Given this list of marker genes TULP3, A4GALT, IGFBP4, CH25H, RASGEF1A, DPYSL4, IL3RA, SQSTM1, P3H2, AMACR (NCBI Gene Id 23600), MYO10, ITGA2, GADD45B, SLC2A14, CSF2, F2RL1 (NCBI Gene Id 7901), FGF11, PLIN2, TARP, HYCC2, ENC1, POU2F1, PLEKHH3, CD83, SLC9A7, CD1B, TJP2, P4HA2, IL18RAP (interleukin 18 receptor accessory protein), DHRS3, CIART, SH3BP4 (SH3 domain binding protein 4), TRAF1, CYSTM1, CCR7, SMAP2, SPAG4, EMP1, GGT5, ADGRG5, PFKFB4, LAMP3, PSAT1, COL6A1, PIM1, SEMA6C (semaphorin 6C), CXCL8, TLE4, BTG1, EPB41, KISS1R, TRIM58, NFIL3, TGM2, ADM (adrenomedullin), TMEFF2, PIK3IP1, DAPK1, CCL3, IL18R1, PLVAP, CCL22, PLEKHA4, CD1A, NT5C3B, FBXO6, OSM, CDKN1C, FNDC3B, SPP1, IL7R, CCDC102A, DUSP5, TMEM116, CCND2, ST3GAL5, DIPK2A, KLF2, MAP1A, SAMSN1, UPK1A, CERCAM, EGFL6, CTSH, NCS1, TUBB2B, RNF217 (ring finger protein 217), CISH, HSPA2, SLC2A10, SLC25A4, SYNE3 (spectrin repeat containing nuclear envelope family member 3), TNFAIP8L3, TRIM46, CBS, PLXNA3, TP53INP2, SOS1, STK17B, STAP1, GPAT3, GNPTAB, FCGR2A, BHLHE40, FAM241A, DDIT4, GPR65, MAPK13, TNFRSF4, COCH, GYPB, PRDM8, HES6, BTG2, MOSPD3, GBP4, NAAA, BBX, SCHIP1, CLEC4A, MAOA, MIIP, HILPDA, OLR1, XIRP1, EGR1, CTXN1, IL4I1, PLAU, ARG2, CD40LG, PGM2L1, GABARAPL1, PRPS1, ST3GAL4, TGFBR1, FCER2, CTNS, GATA2, CXCL10, MTHFD1, BATF3 (NCBI Gene Id 55509), VASN, CDHR1, UBAC1 (NCBI Gene Id 51408), PHTF2, OSBP2, NIBAN2, CALB2, LTB, RGS1, PTGER2, TLE3, HBZ, MOB3B, FPR3, CA2, RHAG, TRIB1, TRIB3, RNF144A, DCPS, PHLDA1, SLC25A37, IGFBP5, RHEBL1, CFH, KRBA1, CST7, P2RX4, SOCS2, HOXB5, ABCA1, CKAP4, IL4R, TTLL7, NOD1, CTSZ, KLF6, MUC1, CCL5, SNTA1 (syntrophin alpha 1), TSC22D2, DAB2, RABGAP1, RAP1GAP, MEX3D, FAM131A, ENPP3, ARL4A, HSPA6, NTSR1, NAALADL1, ANTXR2, PCSK9, GALC, AK3, GNG2, CCL2, SLC6A9 (NCBI Gene Id 6536), CPXM1, NDRG1, here is a description of the gene set: studied in species Homo sapiens Genes up-regulated in CD34+ cells by intermediate activity levels of STAT5A; predominant long-term growth and self-renewal phenotype. The level of transcription factor activity critically regulates cell fate decisions, such as hematopoietic stem cell (HSC) self-renewal and differentiation. We introduced STAT5A transcriptional activity into human HSCs/progenitor cells in a dose-dependent manner by overexpression of a tamoxifen-inducible STAT5A(1*6)-estrogen receptor fusion protein. Induction of STAT5A activity in CD34(+) cells resulted in impaired myelopoiesis and induction of erythropoiesis, which was most pronounced at the highest STAT5A transactivation levels. In contrast, intermediate STAT5A activity levels resulted in the most pronounced proliferative advantage of CD34(+) cells. This coincided with increased cobblestone area-forming cell and long-term-culture-initiating cell frequencies, which were predominantly elevated at intermediate STAT5A activity levels but not at high STAT5A levels. Self-renewal of progenitors was addressed by serial replating of CFU, and only progenitors containing intermediate STAT5A activity levels contained self-renewal capacity. By extensive gene expression profiling we could identify gene expression patterns of STAT5 target genes that predominantly associated with a self-renewal and long-term expansion phenotype versus those that identified a predominant differentiation phenotype. from publication Wierenga AT, Vellenga E, Schuringa JJ (PMID 18779318) Human Gene Set: WIERENGA_STAT5A_TARGETS_UP